Given this list of marker genes NRP1, PLEKHF1, RERE, HBP1, SMAD3, SUSD6, GTF2IRD1, KCTD18, SPATA7, CAMK2G, CHRM3, EFNA1, GATA3, DDIT4, ATXN1, DBP, SPTSSB, TSC22D3, CLDN9, ARID5B, RNF43, UBE2H, PSD3, RXRA, S1PR3, FRMD6, ATP1B1, PTPRK, LRATD2, TNFRSF19, CDH3, ARMC7, CHST15, SLC22A23, SASH1, LAMB1, YPEL2, ZKSCAN1, DLL1, SLC29A3, KLF9, SLC16A5, SEMA3E, ALAD, NPAS3, ATP8B2, INSIG2, TGFB2, MAP3K5, IGSF3, UGT1A6 (UDP glucuronosyltransferase family 1 member A6), TLE1, PBX1, EPHA4, SLITRK6, CPEB4, RGL1, CDYL2, BCL2L1 (BCL2 like 1), TCF7L2, ANK3, SNTB2, CRACDL (NCBI Gene Id 343990), CYB5D2, PPARG, TUFT1, RNF144B, EXT1, KYNU, ZFYVE1, SYTL2, SHROOM3, CDK6 (cyclin dependent kinase 6), TRAM2, TNS3, CGN, EFNB2, ENPP1, PDK4, ESR1, CD55, PTPN21, BTG2, OSBPL10, EDN2, CFAP206, CREB3L2, MEF2D, here is a description of the gene set: Genes bound by ESR1 and down-regulated by estradiol in MCF-7 cells (breast cancer). species: Homo sapiens Estrogen regulates several biological processes through estrogen receptor alpha (ERalpha) and ERbeta. ERalpha-estrogen signaling is additionally controlled by extracellular signal activated kinases such as AKT. In this study, we analyzed the effect of AKT on genome-wide ERalpha binding in MCF-7 breast cancer cells. Parental and AKT-overexpressing cells displayed 4,349 and 4,359 ERalpha binding sites, respectively, with approximately 60% overlap. In both cell types, approximately 40% of estrogen-regulated genes associate with ERalpha binding sites; a similar percentage of estrogen-regulated genes are differentially expressed in two cell types. Based on pathway analysis, these differentially estrogen-regulated genes are linked to transforming growth factor beta (TGF-beta), NF-kappaB, and E2F pathways. Consistent with this, the two cell types responded differently to TGF-beta treatment: parental cells, but not AKT-overexpressing cells, required estrogen to overcome growth inhibition. Combining the ERalpha DNA-binding pattern with gene expression data from primary tumors revealed specific effects of AKT on ERalpha binding and estrogen-regulated expression of genes that define prognostic subgroups and tamoxifen sensitivity of ERalpha-positive breast cancer. These results suggest a unique role of AKT in modulating estrogen signaling in ERalpha-positive breast cancers and highlights how extracellular signal activated kinases can change the landscape of transcription factor binding to the genome. Human Gene Set: BHAT_ESR1_TARGETS_NOT_VIA_AKT1_DN from publication Bhat-Nakshatri P, Wang G, Appaiah H, Luktuke N, Carroll JS, Geistlinger TR, Brown M, Badve S, Liu Y, Nakshatri H (PMID 18838536)